The following is a description of a gene set: The process of regulating the proliferation and elimination of neutrophils such that the total number of neutrophils within a whole or part of an organism is stable over time in the absence of an outside stimulus. species: Homo sapiens Human Gene Set: GOBP_NEUTROPHIL_HOMEOSTASIS, and this is the list of marker genes: MTHFD1, ITPKB, ANXA1, PDE4B, HCAR2, BTK, CCR2, FCAR, PIK3CB (NCBI Gene Id 5291), MPL, TSPAN9, SLC7A11, XKR8, AXL, HMGB1, PIK3CD, FAM3D, CSF1, GCNT4, IL6, MERTK, JAM3, SH2B3